Given this list of marker genes ACTR2, ARPC5L, ARPC3, ARPC4, ARPC2, ACTR3, ARPC1A, ARPC5, ARPC1B, here is a description of the gene set: Human Gene Set: GOCC_ARP2_3_PROTEIN_COMPLEX A stable protein complex that contains two actin-related proteins, Arp2 and Arp3, and five novel proteins (ARPC1-5), and functions in the nucleation of branched actin filaments. studied in species Homo sapiens